Given this list of marker genes CABLES1, CCNH, PSMD8, CCND1, SEM1, PSMD12, CUL1, CKS1B, UBA52, PSMB6, LIN52, E2F4, PSMD1 (proteasome 26S subunit, non-ATPase 1), PSMB4, PSMB1, PSMA6, PSMD13, AKT2, PTK6, MAX, TFDP1, PSMC2, E2F1, PSMB5, LIN9, PSMA4, WEE1, PSMB7, CDKN1A, PSMD11, SKP1, MYC, AKT3, CCNE2, PSMC4, RBL2, CDC25A, UBC, PSMA7, AKT1, CCNA1, LIN54, PSMA5, MNAT1, PSMD14, PSMB2, E2F5, RPS27A, CDK4, PSMA2, PSMB3, TFDP2, RBBP4, UBB, CDKN1B, PSMC5, PSMD6, PSMC6, SKP2, PSMD2, PSMD7, CDK2, PSMC3, RB1, LIN37, PSMA1, PSMD3, PSMC1, CDK7, CCNA2, CCNE1, PSMA3, ADRM1, here is a description of the gene set: Reactome Pathway: Cyclin E associated events during G1/S transition studied in species Homo sapiens part of: G1/S Transition The transition from the G1 to S phase is controlled by the Cyclin E:Cdk2 complexes. As the Cyclin E:Cdk2 complexes are formed, the Cdk2 is phosphorylated by the Wee1 and Myt1 kinases. This phosphorylation keeps the Cdk2 inactive. In yeast this control is called the cell size checkpoint control. The dephosphorylation of the Cdk2 by Cdc25A activates the Cdk2, and is coordinated with the cells reaching the proper size, and with the DNA synthesis machinery being ready. The Cdk2 then phosphorylates G1/S specific proteins, including proteins required for DNA replication initiation. The beginning of S-phase is marked by the first nucleotide being laid down on the primer during DNA replication at the early-firing origins.Failure to appropriately regulate cyclin E accumulation can lead to accelerated S phase entry, genetic instability, and tumorigenesis.